The following is a description of a gene set: Genes down-regulated in splenocytes from Foxp3-Fusion-GFP B6 mice: T reg (FOXP3+) versus T conv (FOXP3-) cells. The aim of this study was to quantify the impact of chimeric Foxp3-GFP protein on the Treg cell transcriptional program. Human Gene Set: GSE37605_TREG_VS_TCONV_C57BL6_FOXP3_FUSION_GFP_DN species: Homo sapiens from publication Darce J, Rudra D, Li L, Nishio J, Cipolletta D, Rudensky AY, Mathis D, Benoist C (PMID 22579475), and this is the list of marker genes: SEL1L, MRI1, ADAMDEC1, GUCY1A1, PKIA, UBASH3A, TMED9, PBX3, ENTPD1, VSIG4, CAV2, BHLHE40, CYB5R1, NIBAN1, NOSTRIN, LRRN3, SEMA4A, NADK, TMEM18 (transmembrane protein 18), SEPTIN10, LCLAT1, C16orf54, PHACTR2, LANCL1, POLR1HASP, S1PR2, PRKACB, ARMC7, CRMP1, THY1 (Thy-1 cell surface antigen), GLIPR2, GLB1, RABL2A, MED10, SOSTDC1, TMBIM4, LENG1, CD81, TOX, ERG28 (ergosterol biosynthesis 28 homolog), STX12, FABP7, DHRS1, TWSG1, IGFBP4, MS4A7, CRISP1, STX11, HS6ST2, NT5E, AKT1, S100A1, SYT11, ACADSB, GFPT2, CHST1, HLA-B, TMEM147, ATP6V0D2, RPL3, MDM1, ALDOC, HSPA5, B3GAT3, HNMT, CACNA2D3, ZDHHC2, SDC1, CD6 (NCBI Gene Id 923, CD6 molecule), RASSF6, SNTG1, SPO11, QPCTL, ITGB2, SLAMF8, IDH1, GCSAM, PSMB8, GNAI3, MRPS26, SLC3A2, IGSF6, TREML4, AARSD1 (NCBI Gene Id 80755), ARL10, LHFPL6, GGH, CTSW, PLEKHB2 (pleckstrin homology domain containing B2), WARS1, CXCR3, COQ3, ITPRIPL1, STAT4, POGLUT3, RBM7, ZBTB42, GSAP, TMBIM6, SEC24A, LONP2, CD68, RIT1, TEDC1 (tubulin epsilon and delta complex 1), CES2, UBD, IKZF2, PRLR, MCU, PINK1, GPR68, DPYSL2, TLCD3A, PIGT, FRMD4B, COA6, MSANTD4, GPR160 (NCBI Gene Id 26996), OSBPL3, FXYD5, PFN2, DHRS7, RAB31, GCA, KDELR1 (NCBI Gene Id 10945), ZFAND3, IFNG, NXT2, SLC22A15 (solute carrier family 22 member 15), C1QC, LMO7, FLT4, MYD88, NIPAL1, GSTM2, RNPEP, ALCAM, FRG1, SPON1 (spondin 1), CLEC4G, PLXNB2, F11R, SNX10, SLC25A11, ZC3H14, ANKRD40, C1orf21, ARPIN, TBX21, MAN2B1, GNAZ, ANXA4, FPR1, EFCAB3, C2orf88, GUCY1B1, VSIR, TSG101, PLS1 (plastin 1), IGF2R, MIR568, CADM1, CHIC1, BMPR1A, RPL18, POMGNT1, FAM78B, GFPT1, RARG, NDFIP1, MTAP, IL13RA1, GLRX, IMP3, FNDC3B, SLPI, RAB21